Given this list of marker genes RPL36P15, MPHOSPH9, OAS2, ENSG00000309728, ANKRD13A, MMP17, RNU4-32P, RNU4-1, TRIAP1, NANOGNBP2, ENSG00000255916, LINC02985, CDK2AP1, CCDC63, ATP2A2, PSMD9, CLIC1P1, CUX2, LINC00173, RN7SKP250, ENSG00000214650, CCDC92, NAA25, LINC00944, BRI3BP, HSPA8P14, USP30, PUS1-AS1, RN7SL387P, LINC02824, ENSG00000258435, GLT1D1, LINC00943, TMEM116, LINC02350, LINC02418, SVOP, LINC02369, RNFT2, PXN, ANAPC7, MIR6763, PXMP2, PPDPFP2, ACACB, NRAV, RN7SL865P, VSIG10, RNA5SP374, RPL35AP30, HCAR1, SRSF9, GPN3, CIT, LRCOL1, RPL12P33, PRKAB1, MYO1H, OAS1, HCAR3, RNU6-717P, MIR3612, RPL11P5, TCHP, ENSG00000302017, MIR1178, ACADS, RBISP3, UBE3B, SIRT4, ZCCHC8, CABP1, RPL21P1, MMAB, ABCB9, RNU4ATAC12P, HSPB8, MIR4472-2 (NCBI Gene Id 100616309), MIR7106, FAM216A, ANKLE2, TMEM132C, ZNF891, SETD1B, SLC25A3P2, DDX54, MIR6761, HIP1R, CAMKK2, CHFR, TMEM132D-AS2, CHFR-DT, THRIL, RAN, HAUS8P1, LINC02359, UBA52P7, TBX5, TCTN1, RASAL1, ENSG00000273499, FBXO21, AK3P6, PITPNM2-AS1, PXN-AS1, SH2B3, OASL, FAM32EP, ALDH2, LINC02411, RPL7AP60, KNTC1, FBXW8, PPP1CC, CLIP1-AS1, KDM2B-DT, RPS6P20, SNORA49, LINC02356, SLC15A4, ENSG00000256286, ADAM1B, GCN1, LINC02441, RPL31P49, CCDC62, ZNF268, RN7SKP197, RPL29P25, SBNO1-AS1, TBX3, RNU7-169P, RNU6-361P, LINC02423, MIR4496, LINC02361 (NCBI Gene Id 100996246), LINC02440, ENSG00000272215, RPL27P12, LINC02825, ZNF664, HCAR2, OAS3, ENSG00000288623 (NCBI Gene Id 128071547), LINC02376, PTPN11, ATXN2-AS, LINC02463, ANAPC5, ENSG00000306956, VPS33A, RILPL1, HSPE1P20, SUDS3, MLXIP, TMED2, ZNF140 (NCBI Gene Id 7699), MIR4497, KMT5A, ENSG00000256609, PTP4A1P2, ENSG00000296521, HECTD4 (HECT domain E3 ubiquitin protein ligase 4), IMMP1LP2, SPRING1, LINC02459, RPS2P5, RN7SKP216, ARF1P2, SDSL, UNG, LINC01089, POLE, FZD10-AS1, LINC01404, COQ5, SLC8B1, ATXN2 (ataxin 2), LINC02460, COPS5P2, TMEM132D, ENSG00000284934, BCL7A, LINC00934, MLEC, BICDL1, PHETA1 (NCBI Gene Id 144717), RNF34, VPS29, MVK, RITA1, DIABLO, MAPKAPK5, ENSG00000309806 (novel transcript, antisense to NCOR2), C12orf76, KCTD10, ZNF10, RFC5, ENSG00000295049, KSR2, IFT81, ENSG00000257997, DAO, ENSG00000302110, MIR1302-1, LINC01486, RNU1-104P, RNA5SP376, SSH1, ZNF84, UBC, LRRC43, TIALD, RPS2P41, HVCN1, PLA2G1B, ZNF84-DT (ZNF84 divergent transcript), RPS6P21, B3GNT4, HNF1A, RAD9B, MIR4498, BRAP, TMEM132B (NCBI Gene Id 84462), FBRSL1, P2RX7, EP400P1, MIR620, NLRP9P1, ENSG00000252459, MAPKAPK5-AS1, MSI1, ENSG00000200112, LINC01257, RPL29P24 (ribosomal protein L29 pseudogene 24), RNA5SP375, RNU6-1077P, PITPNM2, NOS1, RSRC2, RFLNA, MTRFR, RPS11P5, RPH3A, MED13L, CORO1C, LINC02368, RPLP0, AACS, TBX5-AS1, ERP29, RNA5SP373 (RNA, 5S ribosomal pseudogene 373), TCTN2, RPS27P25, EIF2B1, LINC02826, RPL6, SDS, HPD, ENSG00000297923, RNU6-1188P, RNA5SP379, ADGRD1, FOXN4, MIR6861, ENSG00000257279, TMEM132D-AS1, VPS37B, MIR7107, MIR3908, MAP1LC3B2, DTX1, MIR5188, WSB2, MIR4304, CLIP1, OSTF1P1, LINC02457, C12orf43, GALNT9-AS1, NOC4L, PIWIL1, MIR3657, LINC00508, MIR8072, RNU4-2, SELPLG, FZD10, RPS15AP32, RPL22P19, RAB35, ENSG00000300895, NME2P1, ALKBH2, ENSG00000289940, SNRNP35, CFAP251, RHOF, LINC00507, HRK, DYNLL1P4, OGFOD2, ACAD10, TMEM120B, IL31, HMGA1P3, P2RX4, RPS20P31, LHX5-AS1, TPCN1, CCDC60, NCOR2, GTF2H3, LHX5, ENSG00000294918, RN7SKP71, RIMBP2, RNU6-327P, IQCD, ENSG00000257095, MORN3, ENSG00000307806, RNU6-927P, MIR6880, ADGRD1-AS1, LINC02393, ADAM1A, GALNT9, ATP6V0A2, MIR619, DYNLL1, ENSG00000202335, ORAI1, RPL17P37, TAOK3, HNF1A-AS1, USP30-AS1, MIR6762, SNRPGP18, LINC00939, ENSG00000295862, TBX3-AS1, COX6A1, LINC01234, LINC02347, RNU7-170P, DDX55, TESC, ENSG00000248636, TRPV4, KDM2B, SBNO1, RAB35-AS1, PGAM5, RNU6-1017P, RN7SL441P, RN7SL769P, ENSG00000201042, MYL2, LINC02372, ANHX, ARPC3, RNA5SP372, GLTP, RNU6-1004P, DNAH10OS, MIR6760, MIR4700, GOLGA3, SRRM4, RNU6-558P, DHX37, LINC02370, ZNF26, GIT2, RPL23AP67, ARL6IP4, PUS1, LINC02414, PCNPP1, POP5, FAM222A, RNA5SP377, P2RX2, RBM19, SCARB1, LINC01405, LINC02439, TMED2-DT, PPTC7, RNA5SP378, FAM222A-AS1 (FAM222A antisense RNA 1), LINC02419, RNU6-1088P, SNORA70, EP400, TRAFD1, GATC, RILPL2, ULK1, RN7SL508P, PLBD2, LINC02375, DENR, LINC03088, LINC02405, UNC119B, GLULP5, TMEM233, RNF10, ZNF605 (NCBI Gene Id 100289635), NDUFA5P6, PEBP1, CFAP73 (NCBI Gene Id 387885), SPPL3, SNORA9B, DDX51, DNAH10, TESC-AS1, ENSG00000303262, IFITM3P5, CABP1-DT, ELOCP32, STX2, RPL31P52, LINC02415, OASL2P, SFSWAP, here is a description of the gene set: studied in species Homo sapiens Human Gene Set: chr12q24